Given this list of marker genes CACNB3, KCNN2, KCNH6 (NCBI Gene Id 81033), YWHAE, KCNE5, KCNE1, NOS1, KCNK16, KCNQ1, KCNE4, KCNJ2, NOS1AP, CASQ2, SCN2B, MIR1-1, ATP1A1, ATP1B1, CACNA2D1, KCNH2, RNF207, KCNE3, KCNA1, KCNIP2, KCNJ8, KCNJ5, MIR328, KCNE2, DLG1, KCNA5, MIR133A1, CAV1, FLNA, KCNJ3 (potassium inwardly rectifying channel subfamily J member 3), KCND3, here is a description of the gene set: The process in which ions are transported across a membrane such that the membrane potential changes in the direction from the positive membrane potential at the peak of the action potential towards the negative resting potential. Human Gene Set: GOBP_MEMBRANE_REPOLARIZATION_DURING_ACTION_POTENTIAL studied in species Homo sapiens